The following is a description of a gene set: species: Homo sapiens Human Gene Set: HP_ABNORMALITY_OF_THE_URETHRA An abnormality of the urethra, i.e., of the tube which connects the urinary bladder to the outside of the body. Abnormality of the urethra, and this is the list of marker genes: EIF4H, PEX12, AR, RPS29, ADAT3, MAX, B9D1, POR, DPF2, NPM1, CUX1, DVL3, CDKN1C, KDM5B, MLXIPL, FANCE, VAMP7, ELN, WRAP53, DYNC2LI1, ESCO2, PEX14, STAR, CYP11A1, RAF1, PRKACA, PUM1, PRPS1, BRD4, RPS7, MAD2L2, LETM1, ISL1, FOCAD, TMEM237, CYP21A2, MESP2, SMARCD1, POLA1, PRDM16, ORC4, WNT4, FGFR2, ABL1, RAD21, PSMD12, WNT7A, CCDC8, HEATR3, FDFT1, MYMK, ZFPM2, RBBP8, NSD1, PRKACB, FGFRL1, H19, PTPN11, EPG5, REST, B9D2, WNT3, THOC6, KRAS, RAD51C, ACTA1, RAD51, NHP2, RSPO1, MMP23B, WT1, PSPH, TTC8, ZMIZ1, BNC2, MAB21L1, TMEM216, COL7A1, PTDSS1, FIG4 (FIG4 phosphoinositide 5-phosphatase), PUF60, CILK1, FERMT1, TMEM70, PALB2, FANCG (FA complementation group G), CDC6 (cell division cycle 6), IKZF1, XRCC2, SSR4, GTF2IRD2, TRIP13, DIS3L2, BRAF, HSD3B2, NDUFB7, FANCD2, FAT4, OBSL1, CDC45, RPS28, CUL7, RTTN, JMJD1C, PCNT, RPGRIP1L, CPLX1, KLF1, ADA2, PLD1, KANSL1, LFNG, NR0B1, RFC2, SKIC3 (SKI3 subunit of superkiller complex), GTF2I, TAF6, DNAJC19, NKX2-1, HOXD13, HNRNPH1, FLNA, WBP4, TERT, DPP9, B3GLCT, ARID1A, GMNN, RPS15A, TXNDC15, SMARCA2 (NCBI Gene Id 95083), PQBP1, SIAH1, PDPN, CDC42, CDH11, GATAD2B (GATA zinc finger domain containing 2B), RPL35A, KMT2D, GATA4 (NCBI Gene Id 2626), GTF2IRD1, CSPP1, HES7, HOXA13, HSD17B3, FOXC1, HDAC8, KIAA0753, TAPT1, CHRNA3, PAICS, ZNF699, SPRED1, RPL18, RPS27, FANCI, EFEMP2, BAZ1B, TMEM67, CUL4B, EFNB1, NR5A1, CTC1, PDE4D, MAB21L2, LIMK1, CYB5A, HSPG2, COX7B, FZD2, RIN2, UBE2T (NCBI Gene Id 29089), SKI, SIN3A, RPS20, PPP1R12A, DHCR7, KIAA0586, MYRF, HUWE1, PEX1, ARX, CHRNG, BCOR, PITX2, MYMX, SALL1, SRD5A2, LMNA, GRIP1, NDUFA6, COMT, LSS, KLHL41, LRIG2, KDM1A, HBA1, PEX3, RREB1, FANCB, TCF12, ORC1, GLI1, SIX6, H4C11 (H4 clustered histone 11), USB1, DACT1, POLR3A, SPTBN1, MBTPS2, RAC1, DYNC2I2, LAMB3, APC2, PEX16, FANCA, LAMA3, LUZP1, PRKCZ, PLAG1, OGT, DKC1, RPS10, RPL9, RLIM, NCF1, KAT6B, SOX2, UFD1, BRCA2, TMEM94, SRY, NSUN2, KDM3B, TMEM107, FRAS1, NOP10, SETBP1, ARID2, CC2D2A, BBS2, UBR1, TMEM63A, PIEZO2, ZFX, TCTN1, DYRK1A, PEX2, POU6F2, RPS19, TMEM231, PSMB10, KLHL40, ITGA6, RNU12, NELFA, TCTN2, MAPRE2, MAP3K7, LTBP1, VPS35L, EHMT1, CREBBP, PIGG, CDT1, MID1, TCTN3, ZEB2 (NCBI Gene Id 9839), NSD2, ZMPSTE24, PARN, MED25, ROR2, COLEC11, COL3A1 (NCBI Gene Id 1281), KCNAB2, TBX22, EP300, SPEN, PEX26, RPL8, RPS26, FGFR1, HCCS, FREM2, CLIP2, GP1BB, RPL27, WASHC5, SLC31A1, PAX6, UBA1, TSR2, ERMARD, WNT5A, MKKS, KIF7, DHX37 (NCBI Gene Id 84742), BUB1B, KIFBP, NIPBL, HNF1B, NR2F2, SAMD9, PIGA, FBXL4, CLMP, PEX5 (peroxisomal biogenesis factor 5), RERE, DNAJC30, MAMLD1, KAT5, RPS17, GPC4, SCUBE3, STX1A, POLE, SYNGAP1, ZMYM3, GPC3, ATRX, VAC14, PTPRF, COG1, TERC, RPL11, PEX13, CASZ1, MTM1, NDUFA8, SOX11, ARVCF, LRPPRC, AFF4 (NCBI Gene Id 27125), DLL3, CCDC22, ARL6IP6 (NCBI Gene Id 151188), PLEC, SMARCE1, HBA2, CDCA7, RPGRIP1, SUCLG1, TBL2, COLEC10, SMAD4, TBX1, BDNF, SMC1A, NDUFB11, DYNC2H1, C2CD3, HIRA, NAA10, USP9X, ZMYM2, RFWD3, MED12L, ALG12, RPL26, IFT80, SOX9, MCTP2, TP63, HYLS1, TMEM270, MKS1, UBE2A (ubiquitin conjugating enzyme E2 A), HLA-B, WDR35, DVL1, RIPPLY2, SEC24C, ANKRD11, TRIM28, NDUFS4, PEX19, LIG4, RPL5, TYMS, MMP1, FLT4, METTL27, MTOR, SMG8, FANCM, ATR, SLC25A10, WWOX, EVC, GABRD, TUBB, CYP17A1, ITGB4, BICRA, RPL15, MAP3K1 (NCBI Gene Id 4214), VPS37D, CDC42BPB, FANCF, RPL31, PEX6, HMGA2, SMS, TINF2, ACBD6, SMARCA4, EVC2, DCHS1, SETD5, NEB, IGF2, CTBP1, ARID1B, MECP2, RPL35, MED12, MAP2K1, ARCN1, ZIC3, LMOD3, MYH3, ORC6, BRIP1, DYNC2I1, RPL10, SMC3, PEX11B, TONSL, PEX10, FGD1, FKBP6, FOXF1, HPSE2, SRCAP, OTUD5, GLI3 (GLI family zinc finger 3), SLX4, FANCL, SMARCB1, SMCHD1, FANCC, RTEL1, CARS1, PNPLA6, CEP290, SOX4, GATA1, RPS24, UBE4B, PKP1 (plakophilin 1), BRCA1, ERCC4, TFAP2A, CHRM3, PIGN, FBLN5, GNA11, KDM6A, SMARCC2, CEP152 (NCBI Gene Id 23701), LAMC2, ATP6AP2, GRB10, DPYSL5, NOTCH2, BUD23, TRIM8